Given this list of marker genes CD68, SLC37A4, BABAM2, ERP29, NDUFAF4, HADH, MGST2, NDUFA1, DGLUCY, APOE, HSD17B8, STARD13, UBE2L6 (NCBI Gene Id 9246), BNIP3, QDPR, ARHGAP25, DYRK4, CTSF, MAP1S, NCF4, TMEM59, RHOBTB1, PEX12, BLNK, GM2A, TMEM106B, TBC1D16, NSL1, UGP2, GATM, SLC8B1, B3GNT2, UBL3, CD300A, NRP2, EFCAB11, AP2A2, APOC1, KDSR, CD59, CHCHD7, IGF1, NTAN1, ACAT1, VAT1, PLD1, HS2ST1, CCDC51, AP1AR, SLC47A1, SUCLG2, HPS1, DUSP7, TCEAL1, CRTAP, SLC38A7, ACP5, ARHGAP12, MTSS1, F13A1, UBE3B, UBA7, SPATS2L, ACO1, TIMP2, CDK4, COQ7, EPB41L2, CDKL3, MRPS33, PILRA, SCLY, SORD, PGAP3, UAP1L1, DSC2, CTSD (cathepsin D), ANKRD46, SLC17A5, ZKSCAN4, ZDHHC24, SNTB2, CREG1, GPD1L, P2RY13, TM7SF3, CASD1, AHCY, CYBC1, NDRG3, MMP12, SLC38A6, CFD, IDH1, ST6GAL1, TRIM32, ANXA4, SLA, CDR2L (NCBI Gene Id 30850), ALDH9A1, MCUR1, UBAP2L, GNS, ENOSF1, SLC2A9, ABCA2, PFKM, EPHX1, PBXIP1, C1QB, MGST3, FECH, FAHD2A, FHIT, TSPAN14, PANX1, SKIC3, CD81, SCARB1 (scavenger receptor class B member 1), ZC3H3, APPL2, AKR1A1, PCSK5, FOXRED2, SIGIRR, ITSN1, PRKD3, P4HTM, SGPP1, STX3, RAD51AP1, RRAGD, BLTP2, IL11RA, SCPEP1, NENF, SIGLEC1, TBC1D5, TSPAN4, AKAP11, LY96, ECM1, HSPB1, MAN1A1, IQCG, OSBPL3, UQCRQ, ABCA1, PLAU, SPP1, ANKRD13C-DT, P2RY14, PCBD1, ZMYM6, SECTM1, RLIG1, HRH1, CR1, IGF2R, PIGP (NCBI Gene Id 53821), ABCC5, SDC3 (NCBI Gene Id 9672), NDUFA4, JADE2, SYK, MFHAS1, RENBP, RBMS1, GUSB, CD99, PIK3R1, IGSF6, ALDH6A1 (NCBI Gene Id 4329), CDR2, SLC39A4, UQCC1, CCL8 (NCBI Gene Id 96488), HIBCH, AIFM1, FOLR2, MDH1, BLVRB, TNFSF12, CASP6, TMEM160, WDR7, CST3, TXNRD3, HPF1, COMMD9, DBP, RNF19A, SLC12A7, QPRT, ZNF589, FCGBP, GAS7, SMIM8, DAG1, MAT2A (NCBI Gene Id 4144), here is a description of the gene set: Human Gene Set: GSE36826_NORMAL_VS_STAPH_AUREUS_INF_SKIN_DN Genes down-regulated in skin: uninfected versus S. aureus infection. studied in species Homo sapiens from publication Cho JS, Guo Y, Ramos RI, Hebroni F, Plaisier SB, Xuan C, Granick JL, Matsushima H, Takashima A, Iwakura Y, Cheung AL, Cheng G, Lee DJ, Simon SI, Miller LS (PMID 23209417) Neutrophil abscess formation is critical in innate immunity against many pathogens. Here, the mechanism of neutrophil abscess formation was investigated using a mouse model of Staphylococcus aureus cutaneous infection. Gene expression analysis of S. aureus-infected skin revealed that induction of neutrophil recruitment genes was largely dependent upon IL-1beta/IL-1R activation. Unexpectedly, using IL 1beta reporter mice, neutrophils were identified as the primary source of IL-1beta at the site of infection. Furthermore, IL-1beta-producing neutrophils were necessary and sufficient for abscess formation and bacterial clearance. S. aureus-induced IL 1beta production by neutrophils required TLR2, NOD2, FPRs and the ASC/NLRP3 inflammasome. Taken together, IL-1beta and neutrophil abscess formation during an infection are functionally, spatially and temporally linked as a consequence of direct IL-1beta production by neutrophils.